Given this list of marker genes Cfb, Cpeb3 (NCBI Gene Id 208922), Tor3a, Hsd11b2, Mest, Bgn, Ifi44, Tor1aip1, Tmem167, Ppp1r10, Pmepa1, Irf9, Cdk5r1, Tspan33 (NCBI Gene Id 71762), Steap4, Gbp6, Ccl9, Slc24a3, Dkk3, Egf (NCBI Gene Id 99717), Cxcr5, Plec, Ogn, Cd2, Igtp, Abi3bp, Ifit1, Ccl2, Tes3-ps, Txndc16, Samhd1, Sp100, Ifit2, Tmem140, Uba7, Themis2, Mx1, Rfxank, Zfp672, Zfp503, Parp9, Ebna1bp2, Prss23, Usp18 (NCBI Gene Id 68782), Slc9a8, Ifih1, Eln, Elk1, Gbp2, Osgin2, Trim34a, Isg15, Mocs1, Casd1, Zbp1, Ghr, Actb, Ifit3 (NCBI Gene Id 433243), Vdac1, Fjx1, Pfdn5, Irf2 (interferon regulatory factor 2), Tlr3, Gstm1, Oxa1l, Mrpl57, Cmpk2, N4bp2l1, Parp14, Wfdc21, Lifr, Hipk2, Adcy3, Tacr2, Parp3, Adcy7, Dpf3, Reck, Rtp4, Boc, Trafd1, Necab2, Resf1, Slfn4, Eif2ak2, Trim30a, Sod2, Trim25, Socs1, Nedd9, C3, Aqp1, Iapp, Oas1b, Casp7, Hoxb5, Col9a1 (NCBI Gene Id 12839), Mepce, Lipa, Abcc8, Capn6, Kctd12, Prf1, Usp25, Pdgfrb, Fcgr4, Oas2, Irgm2, Cyp2c29, Ly75, Inhbb, Fas, Dnajc27, Bst2, Kalrn, Ccn5, Gbp7, Hsd11b1, Irf1, Irs1, Tgtp1, Tlr2, Myoc, Nck1, Lce1a2, Fstl1, Oas1a, Dapk2, Irf7, Elovl4, Cdon, Col5a3, Trib2, Ddx60, Col4a3, Irgm1, Kcnmb2, Phldb2, Nacc2, Slfn2 (schlafen 2), Sfxn2, Rnf144b, Ifi47, Dnm3, Adar, Gtf3c6, Nkx2-3, Col5a2, Oasl2, Cyp2b19, Rsad2, Pou3f4, Clip1, Pthlh, Nxnl2, Lypd8l, Pcdhb22, Nmnat1, Slfn3, Tubb4b, Ifi211, Stat1, Zfp931, Septin6, Tmt1a, Rbm43, Pla2g2e, Cntnap4, Apol9b, Hhat, Fes, Sp110, Trim8, Tap2, Trp53inp1, Txnip, Pcdhb17, Cxcl10, Miga2, Pes1, Ccl7, Ighg1, Ihh, Nnmt, Selenop, Ifi27, Pde7a, Fbxw2, BC023105, Helz2, Ikbkb, Sycp3, Enc1, Uroc1, Mmd, Kng1, Ifi35, Bcr, Rtl6 (NCBI Gene Id 223732), Rin2, Csf1, Grhl2, Cp, Hoxb7, Ubxn2b, Ifi203, Gbp4, Dmp1, Psmb10, Senp1, Tmpo, Iigp1, Osr1, H2-T23, Wfdc18, Hoxb8, Kcna6, Rbmx, Lgals3bp, Trim21, Angpt1, Ncl, Igfbp7, Patz1, Prelp, Neurog3, Dlc1, Col3a1, Atg10, Stk11ip, Mx2, Cdca3 (NCBI Gene Id 80405), Trim12a, Parp12, Cep112, Crhr1, here is a description of the gene set: from publication Graessmann M, Berg B, Fuchs B, Klein A, Graessmann A (PMID 17160024) Mouse Gene Set: GRAESSMANN_RESPONSE_TO_MC_AND_SERUM_DEPRIVATION_UP Genes up-regulated in ME-A cells (breast cancer, sensitive to apoptotic stimuli) upon serum deprivation for 22 hr in the presence of medium concentrate (MC) from ME-C cells (breast cancer, resistant to apoptotic stimuli). studied in species Mus musculus Impairment of the complex regulatory network of cell death and survival is frequently the reason for therapy resistance of breast cancer cells and a major cause of tumor progression. We established two independent cell lines from a fast growing mouse breast tumor (WAP-SVT/t transgenic animal). Cells from one line (ME-A cells) are sensitive to apoptotic stimuli such as growth factor depletion or treatment with antitumor agents (e.g. doxorubicin). Cells from the second line (ME-C cells), which carry a missense mutation at the p53 codon 242, are very insensitive to apoptotic stimuli. Co-cultivation experiments revealed that the ME-C cells mediate cell death resistance to the ME-A cells. Microarray and Western blot analysis showed that osteopontin (OPN) is selectively overexpressed by the ME-C cells. This glycoprotein is the most abundant protein secreted by the ME-C cells and we obtained strong indications that OPN is the main antiapoptotic factor. However, the OPN containing ME-C cell medium does not alter the expression level of pro- or antiapoptotic genes or known inhibitors of apoptosis (IAPs). Its signaling involves mitogen-activated protein kinase (MAPK)/extracellular signal-regulated kinase (ERK) kinase (MEK)1/2 as the kinase inhibitor PD98059 restores apoptosis but not the Akt inhibitor. In the ME-A cells, mitochondrial cytochrome c release occurs with and without external apoptotic stimuli. OPN containing ME-C cell medium does not prevent the mitochondrial cytochrome c release and caspase-9 processing. In serum starved ME-A cells, the OPN containing ME-C cell medium prevents caspase-3 activation. However, in doxorubicin-treated cells, although apoptosis is blocked, it does not inhibit caspase-3. This indicates that the ME-A cells distinguish between the initial apoptotic stimuli and that the cells possess a further uncharacterized control element acting downstream from caspase-3.